The following is a description of a gene set: Genes down-regulated in cancer endometrium samples compared to the normal endometrium. Human Gene Set: WONG_ENDMETRIUM_CANCER_DN studied in species Homo sapiens Endometrial cancer is the third most common gynecologic malignancy and the ninth most common malignancy for females overall in Hong Kong. Approximately 80% or more of these cancers are endometrioid endometrial adenocarcinomas. The aim of this study was to reveal genes contributing to the development of endometrioid endometrial cancer, which may impact diagnosis, prognosis and treatment of the disease. Whole-genome gene expression analysis was completed for a set of 55 microdissected sporadic endometrioid endometrial adenocarcinomas and 29 microdissected normal endometrium specimens using the Affymetrix Human U133 Plus 2.0 oligonucleotide microarray. Selected genes of interest were validated by quantitative real-time-polymerase chain reaction (qRT-PCR). Pathway analysis was performed to reveal gene interactions involved in endometrial tumorigenesis. Unsupervised hierarchical clustering displayed a distinct separation between the endometrioid adenocarcinomas and normal endometrium samples. Supervised analysis identified 117 highly differentially regulated genes (>or=4.0-fold change), which distinguished the endometrial cancer specimens from normal endometrium. Twelve novel genes including DKK4, ZIC1, KIF1A, SAA2, LOC16378, ALPP2, CCL20, CXCL5, BST2, OLFM1, KLRC1 and MBC45780 were deregulated in the endometrial cancer, and further validated in an independent set of 56 cancer and 29 normal samples using qRT-PCR. In addition, genes were differentially regulated in late-stage cancer, as compared to early-stage disease, and may be involved in tumor progression. Pathway analysis of the expression data from this tumor revealed an interconnected network consisting of 21 aberrantly regulated genes involved in angiogenesis, cell proliferation and chromosomal instability. The results of this study highlight the molecular features of endometrioid endometrial cancer and provide insight into the events underlying the development and progression of endometrioid endometrial cancer. from publication Wong YF, Cheung TH, Lo KW, Yim SF, Siu NS, Chan SC, Ho TW, Wong KW, Yu MY, Wang VW, Li C, Gardner GJ, Bonome T, Johnson WB, Smith DI, Chung TK, Birrer MJ (PMID 17043662), and this is the list of marker genes: PDGFRA, OSR2, DPP6, RBP7, LMOD1, TSHZ3 (teashirt zinc finger homeobox 3), TWIST2, WT1, DCN, CNRIP1, MME, GFRA4, OLFM1, CRISPLD2, EFS, SLC18A2, MASP1 (MBL associated serine protease 1), XYLT1, TBX3, F10 (coagulation factor X), COX7A1, SRPX, LTBP4, CD248, SYNPO2, EFEMP1, CTSW, OGN, GNLY, WNT4 (Wnt family member 4), GLT8D2, ATP8A2, KLRC2, PLEKHH2, EHD2, TNXA, GAS6, EMILIN1, PID1, NDN, SLC24A3, RORB, IGFBP6, FBXO32, COL3A1, HGF, PEG3, PAPPA, RAMP1, TRO, TMEM132C, KIF26A, ADAMTS5, EDNRB, NID1, MIR503HG, PWWP3B, RIPOR3, P2RY14, ALDH1A2, JPH4, SIN3B, MICU3, ADGRD1, PARM1 (NCBI Gene Id 25849), TCEAL7, TRPC1, RUNX1T1, FBN1, SCARA5, ECM2, LDB2, FLRT2, SFRP4, FOXL2, HIC1 (HIC ZBTB transcriptional repressor 1), HAND2-AS1, VGLL3